The following is a description of a gene set: Any process that modulates the frequency, rate or extent of neuromuscular junction development. species: Mus musculus Mouse Gene Set: GOBP_REGULATION_OF_NEUROMUSCULAR_JUNCTION_DEVELOPMENT, and this is the list of marker genes: Slc18a3, Six1, Dctn1, Lin7a, Lin7c, Ptn, Mycbp2, Colq, Agrn, Pdzd11, Gsk3b, Musk, Lin7b, Six4